The following is a description of a gene set: Genes negatively differentially expressed in cell type: CD4+ T cell upon treatment with cytokine: IL-17B in mouse lymph nodes in vivo. Mouse Gene Set: CUI_T_CELL_CD4_IL17B_RESPONSE_DN species: Mus musculus from publication Cui A, Huang T, Li S, Ma A, Pérez JL, Sander C, Keskin DB, Wu CJ, Fraenkel E, Hacohen N (PMID 38057668) Cytokines mediate cell-cell communication in the immune system and represent important therapeutic targets. A myriad of studies have highlighted their central role in immune function, yet we lack a global view of the cellular responses of each immune cell type to each cytokine. To address this gap, the authors created the Immune Dictionary, a compendium of single-cell transcriptomic profiles of more than 17 immune cell types in response to each of 86 cytokines (>1,400 cytokine-cell type combinations) in mouse lymph nodes in vivo. A cytokine-centric view of the dictionary revealed that most cytokines induce highly cell-type-specific responses. For example, the inflammatory cytokine interleukin-1β induces distinct gene programmes in almost every cell type. A cell-type-centric view of the dictionary identified more than 66 cytokine-driven cellular polarization states across immune cell types, including previously uncharacterized states such as an interleukin-18-induced polyfunctional natural killer cell state., and this is the list of marker genes: H2-Eb1, Lars2, Cd74 (NCBI Gene Id 16149), H2-Ab1, Hspa1a